The following is a description of a gene set: studied in species Homo sapiens from publication Busconi L, Bauer JW, Tumang JR, Laws A, Perkins-Mesires K, Tabor AS, Lau C, Corley RB, Rothstein TL, Lund FE, Behrens TW, Marshak-Rothstein A (PMID 18025183) Human Gene Set: GSE6674_UNSTIM_VS_PL2_3_STIM_BCELL_UP Genes up-regulated in B lymphocytes: control versus PL2-3 (Chromatin IC). We have previously shown that rheumatoid factors (RF) produced by Fas-deficient autoimmune-prone mice typically bind autologous IgG2a with remarkably low affinity. Nevertheless, B cells representative of this RF population proliferate vigorously in response IgG2a/chromatin immune complexes through a mechanism dependent on the sequential engagement of the BCR and Toll-like receptor 9 (TLR9). To more precisely address the role of both receptors in this response, we analyzed the signaling pathways activated in AM14 B cells stimulated with these complexes. We found that the BCR not only serves to direct the chromatin complex to an internal compartment where it can engage TLR9 but also transmits a suboptimal signal that in combination with the signals emanating from TLR9 leads to NF-kappa-B activation and proliferation. Importantly, engagement of both receptors leads to the upregulation of a group of gene products, not induced by the BCR or TLR9 alone, that include IL-2. These data indicate that autoreactive B cells, stimulated by a combination of BCR and TLR9 ligands, acquire functional properties that may contribute to the activation of additional cells involved in the autoimmune disease process., and this is the list of marker genes: PIP4K2B, STX1B (NCBI Gene Id 6805), ELANE, HACD4, RNF38, NGLY1, MARCHF3, MIR200B, CLEC12A, STING1, SFXN3, HIPK1, SMYD2, KLHL40, SERPINB10, CLEC1B, GPR12, B3GNT8, MRPS18B, CENPI, NOLC1, POLR1B (NCBI Gene Id 88998), DDI1, SLC17A9, FBXL20, PDZD7, FAM234A (NCBI Gene Id 83986), SELPLG, RPS3, ZDHHC9, TCP11L2, RACK1, HOPX, ARNT2, NOMO1, PAQR7, TMEM176A, KLK9, ACY1, ITM2B, TRUB1, GPX1, RABAC1, SLC22A20P, MIR25, KMT5C, KMO, CD9, PRC1, ABHD15, TDP1, NIT2, FLNA, CD177, RRP1B, IFNGR1, RIMKLA, P2RX3, CELF2, PALM, COX8BP, LIN28B, RORB, CTDSPL, PUS7, DNAJC25, LYRM4, FAM168B, SUCLG2, SLC25A3, ANGEL1, RNASEH2A, TAF1A, KCNQ4, KIF20B, TOMM40, ADAM22, LRRC14B, NHP2, ACAT1, SEZ6, LBX1, TDRD5, NID1, APOBEC1, WDR41, GABRR2, KCNIP3, MEIS1, QPCT, ADRB3, FOXO3 (NCBI Gene Id 2309), ITSN1, PCYT2, TOMM22, GRIP1, NOL9, ARAP3, SPNS2, ACADM, DNAJC28, DFFA, TMEM106C, SERPINA7, BZW2, SIGIRR, CYP27A1, APLP2, GAMT, MSRB2, PCDH20, IRAG2, MCCC2, SERPINA11, KCNS3, GKN2, PHACTR2, GART, MRM1, BPHL, CLEC7A, GHRL, HSD17B8, SMPDL3A, COX8A, SELENOP, MYO9A, RPL3, SYT15, GOT2, FAHD1, WDHD1, SERINC3, TMEM154, FAM43A, VAV3, GNA15, KIF26B, DNAJC9, TBC1D31, GLRA1, ABCD2, TCF3, H2AC15, KLHL21 (kelch like family member 21), COPS6, NPAS3, CHEK2, AGPAT4, SLC1A3 (solute carrier family 1 member 3), GJB4